Given this list of marker genes PGLYRP1, GNA12, CD38, HPGDS, CD7, ITM2A, LTF, CTNNA1, IGF2BP2, TNS3, IGLL1, MMP8, SFXN3, NDFIP1, ARHGEF3, HSPB1, DLC1, SUCLG2, IGHM, PRR5L, B4GALT6, CAMP, CEBPA, MEST, ATN1, BASP1, GALC, SEL1L3, CEACAM8, HOXB2, TRIB1 (tribbles pseudokinase 1), TRDC, HOXA9, LCN2, SLC16A1, TBL1X, TUBB6, here is a description of the gene set: BACKGROUND: In patients with acute myeloid leukemia (AML) a combination of methods must be used to classify the disease, make therapeutic decisions, and determine the prognosis. However, this combined approach provides correct therapeutic and prognostic information in only 50 percent of cases. METHODS: We determined the gene-expression profiles in samples of peripheral blood or bone marrow from 285 patients with AML using Affymetrix U133A GeneChips containing approximately 13,000 unique genes or expression-signature tags. Data analyses were carried out with Omniviz, significance analysis of microarrays, and prediction analysis of microarrays software. Statistical analyses were performed to determine the prognostic significance of cases of AML with specific molecular signatures. RESULTS: Unsupervised cluster analyses identified 16 groups of patients with AML on the basis of molecular signatures. We identified the genes that defined these clusters and determined the minimal numbers of genes needed to identify prognostically important clusters with a high degree of accuracy. The clustering was driven by the presence of chromosomal lesions (e.g., t(8;21), t(15;17), and inv(16)), particular genetic mutations (CEBPA), and abnormal oncogene expression (EVI1). We identified several novel clusters, some consisting of specimens with normal karyotypes. A unique cluster with a distinctive gene-expression signature included cases of AML with a poor treatment outcome. CONCLUSIONS: Gene-expression profiling allows a comprehensive classification of AML that includes previously identified genetically defined subgroups and a novel cluster with an adverse prognosis. species: Homo sapiens from publication Valk PJ, Verhaak RG, Beijen MA, Erpelinck CA, Barjesteh van Waalwijk van Doorn-Khosrovani S, Boer JM, Beverloo HB, Moorhouse MJ, van der Spek PJ, Löwenberg B, Delwel R (PMID 15084694) Genes that best predicted acute myeloid leukemia (AML) with mutations in CEBPA. Human Gene Set: VALK_AML_WITH_CEBPA